Given this list of marker genes PRPS1, SLC52A3, CBFA2T3, CTPS2 (CTP synthase 2), BAD, IMPDH2, ABCC6 (NCBI Gene Id 5823), NDUFB7 (NCBI Gene Id 4713), EP300, MTOR, PAPSS2, KARS1, PUDP, OGDHL, ME2, OGDH, HPRT1, PGK1, PRXL2C, PDE4A, EIF6, PPARA, BEND3, CMPK1, DLG2, OLA1, TP53, SLC25A18, TSPO, ABCC9, PPP2CA, IDH1, G6PD, MT-ATP8, GIMAP7, ADCY4, DUT, UPP1 (NCBI Gene Id 7378), TK2, ENO1, AMPD3, NDUFS6, PRTFDC1, COX11, TKT, SULT1C3, PFKM, IL4, NDUFA12, IDH2, AK1, NUDT9, HSPA1A, HK1, MDH2, SULT1A2, ZBTB20, NDUFA11, MBD4, RPTOR, APRT, MYH6, ATP5MF, DMAC2L, PID1, GPD2, ATP5PB, PDE8B, NDUFC1, FIS1, AK4, ATP5PO, ATP5MG, EFL1 (elongation factor like GTPase 1), GIT1, NOX1, DGUOK, CDA, NDUFB11, ATP6V1B1, ASMTL, ATP1A2, IER3, APP, CTNS, UPB1, GPI, SIRT6, RPE, TREX1, BCL2L13, PGD, NT5E, ENTPD4, NADSYN1, TIGAR, ARNT, RPIA, GDA, TPST2, ENO4, SLC25A12 (solute carrier family 25 member 12), PRKAA2, GUCY2F, ATP5MK, DCK, MT-ATP6, MTHFD1, NDUFB3 (NADH:ubiquinone oxidoreductase subunit B3), ITPA, TREM2, NMRK1, CTPS1, IMPDH1, ADK, PRKACA, NDUFB9, VPS9D1, UCK1, NMNAT3, LIPA, ALDH1L2, PDE8A, SULT1E1, MYH4, PRPS2, HAAO, HINT1, SHPK, ATP5MGL, RRM1, PAPSS1, IDO1, PTHLH, AK6, HSPA8, ARL2, TDG, RPEL1, SELENON, GUCA1ANB-GUCA1A, MT-ND3, NMNAT1, ATP5F1EP2, KMO, NPR2, NDUFS2, ADCY9, GALK1, DPYD, KYNU, OGG1, NUDT13 (NCBI Gene Id 51055), DHTKD1, SLC25A25, GPD1 (glycerol-3-phosphate dehydrogenase 1), PDE1A, RAN, RD3, NDUFS4, FIGNL1, OPA1, NDUFA6, GUK1, PARK7, NME9, NDUFA5, PGAM1, AMPD1, AMPD2, PGK2, SDHB, PKM, LETMD1, PAICS (phosphoribosylaminoimidazole carboxylase and phosphoribosylaminoimidazolesuccinocarboxamide synthase), PNP, SLC4A7, BPGM, DERA, NMRK2 (nicotinamide riboside kinase 2), SULT2A1, HDAC4, ADSL, NNT, NDUFS7, ADCY5, NDUFS1, GART, ATP5MC1, NDUFA13 (NADH:ubiquinone oxidoreductase subunit A13), ATP1B1, TALDO1, ALDOC, NDUFA2, DCXR, MT-ND4L, ENTPD5, NUDT4, ADCY10, SHMT1 (serine hydroxymethyltransferase 1), MFN1, ATPSCKMT, NAPRT (nicotinate phosphoribosyltransferase), NDUFS3, INSR (NCBI Gene Id 3643, insulin receptor), NOCT, UCKL1, FOXK1, NUDT11, NUPR1, NPR1, IFNG, RBKS, NUDT17, MAPDA, NDUFA1, ATP5PD, DCTPP1, ATP6V0C, OGT, SLC25A22, TPST1, VCP, ADCY1, NUDT2, PTH, NDUFA7, INS, MIR675, FOXK2, ATP5F1D, GUCY1B1, NUDT10, SLC4A1, NDUFA9, ATP5MC3, PRPS1L1, GAPDH, ATP5MC2, CAD, TGFB1, ACTN3, NT5C1B, AK2, SDHC, PSEN1, ACACB, AK8, PRPSAP1, NTHL1, MYH8, DDIT4, UCP2, ENTPD7, ATIC, TJP2, FHIT, NDUFA3, AK9, NPPA, NCOR1, NADK2, CASK, HK2, MYH7, JMJD8, NDUFB2, ADCY2, NT5C, UPRT, MACROH2A1, NDUFC2, PGM1, ATP5MJ, GUCA1A, UNG, MYH3 (NCBI Gene Id 4621), IGF1, ATP6V1B2, NT5M, PFKL, PGAM4, ATP5PF, NT5C3A, PFAS, NDUFV1, MT-ND1, SPHK2, GUCY2D, PDE10A, MT-ND5, CARD11, NUDT12, MTHFD2L, NUDT4B, HIF1A, NME7, PDE7A, UCHL1, NUDT18, ALDH1L1, NDUFA10, NMNAT2, SULT2B1, GPD1L, NME3, NT5C3B, ALDOA, MT-ND2, SULT1A3 (sulfotransferase family 1A member 3), NDUFB10, KAT2B, PC, GOT2, SLC2A6, PDE7B, MAGI3, EPHA2, LACC1, TYMS, UCK2, AK7, ATP5F1B, PGAM2, PRKN, NUDT5, ENTPD1, NT5C1A, ACO1, XDH, HSPA1B, GUCY1A2, GUCY2C, QPRT, NME2, LRRK2, H6PD, NDUFS5, GOT1, PFKFB1, BPNT1, ABHD14B, NUDT15, GMPR, ADPGK, HKDC1, DNAJC30, MTCH2, ATP5IF1, MT-ND6, HTR2A, GCK, ATP6V1A, ASPDH, MLXIPL (MLX interacting protein like), NEIL1, DCTD, SLC25A13, GUCY1A1, SULT1B1, LRGUK, NDUFV3, MDH1B, ALDOB, CD38, NDUFB8, CNP, NME2P1, NDUFA8, SULT1A1, ATP5F1E, ENPP3, AFMID, UMPS, SAMHD1, ACP3, FLAD1, PRKAG3, ATP5F1C, SULT1A4, TMSB4X, NT5C2, GARS1, DHODH, PRPSAP2, PRKAG2, RNASEH2B, ADCY3, SMUG1, TRIM63, LDHB, PFKFB2, FMO2, GMPR2, NDUFB4, NAXE, NME5, SRC, TAFAZZIN, MPP1, DNM1L, DLG1, TP53I3, SLC4A4, DPYS, GMPS, UQCC3, MLST8, COL6A1, NDUFAB1, AK5, CACNB4, NPPB, NEIL2, BLOC1S6 (biogenesis of lysosomal organelles complex 1 subunit 6), ADCY6, ADA, REXO2, MT-ND4, GAPDHS, STAT3, ATP5ME, PRKAG1, HK3, RORA, RHOQ, STOML2, RAB23, NADK, NDUFS8, MFSD8, ATP5F1A, NAXD, ADCY7, PDE9A, GTPBP1, NDUFB1, FAM3A (NCBI Gene Id 60343), ANTKMT, RFK, MAP2K1, ADSS1, NDUFB5, FLCN, LDHA, PDE4C, PARP1, ZBTB7A, P2RX7, PFKP, NUDT3, SDHA, ADSS2, PPAT, ADCY8, ENO2, PDE5A, ENPP1, RRM2, TBPL1, DNPH1, NDUFV2, NPPC, ATP7A, PDE4B, NDUFB6, DTYMK, TYMP, NME6, CLPX, PKLR, NME4, NME1, GNAI3, PFKFB3 (NCBI Gene Id 5209), PARG (poly(ADP-ribose) glycohydrolase), CMPK2, SDHD, PGLS, UPP2, NUDT16, PINK1, PRKAA1, RRM2B, FBP1, SULT1C4, ENO3, ME1, PDE4D, AK3, SARM1, NAMPT, IDO2, TPI1, ACMSD (NCBI Gene Id 130013), FKRP, LDHC, SLC25A11, MDH1, PDE2A, here is a description of the gene set: studied in species Homo sapiens Human Gene Set: GOBP_NUCLEOTIDE_METABOLIC_PROCESS The chemical reactions and pathways involving a nucleotide, a nucleoside that is esterified with (ortho)phosphate or an oligophosphate at any hydroxyl group on the glycose moiety; may be mono-, di- or triphosphate; this definition includes cyclic nucleotides (nucleoside cyclic phosphates).